The following is a description of a gene set: Mouse Gene Set: GOBP_CIRCADIAN_REGULATION_OF_GENE_EXPRESSION species: Mus musculus Any process that modulates the frequency, rate or extent of gene expression such that an expression pattern recurs with a regularity of approximately 24 hours., and this is the list of marker genes: Mta1, Ppara, Bmal1, Cartpt, Hnf1b, Prkg2, Mybbp1a, Hdac3, Per1, Nr0b2, Nudt12, Ppp1cb, Egr1, Relb, Ncor1, Atf4, Ciart, Per3, Ngfr, Ahr, Cavin3, Lgr4, Rorc, Sirt6, Nr1d1, Kdm2a, Kdm8, Cry1, Csnk1e, Id2 (inhibitor of DNA binding 2), Hdac2, Pml, Rora, Gfpt1, Top1, Per2, Hnrnpu, Mycbp2, Sirt1 (sirtuin 1), Zfhx3, Noct, Cry2, Hdac1, Rai1, Drd3, Ppp1ca, Ppp1cc, Csnk1d, Maged1, Pasd1, Kmt2a, Huwe1, Prmt5, Nrip1, Crem, Ncoa2, Rbm4, Npas2, Ppargc1a, Drd2, Rbm4b, Kdm5a, Bmal2, Usp2, Zpbp2, Nampt, Mc3r, Bhlhe40, Ogt, Clock, Bhlhe41